The following is a description of a gene set: studied in species Homo sapiens Atrophy of alveolar ridges Human Gene Set: HP_ATROPHY_OF_ALVEOLAR_RIDGES, and this is the list of marker genes: ELANE, C1R, CTSC, LYST, C1S